The following is a description of a gene set: The developmental process pertaining to the initial formation of a heart valve from unspecified parts. This process begins with the specific processes that contribute to the appearance of the discrete structure and ends when the structural rudiment is recognizable. Human Gene Set: GOBP_HEART_VALVE_FORMATION studied in species Homo sapiens, and this is the list of marker genes: RHOA, GJA5, TWIST1, HEY2, ZFPM1, HEY1, OLFM1, EFNA1, DCHS1, TBX20, SCX, CDH11 (cadherin 11), SOX9, NOTCH1, SMAD4, GATA4